Given this list of marker genes Mgat4d (MGAT4 family, member C), Srd5a3, Entpd5, Dolpp1, Nus1, Tusc3, Rpn2, Alg2, Pmm1, Rpn1, Frey1, Tmem258, Mgat2, Mgat4a, B4galt7, Dolk (NCBI Gene Id 227697), Mgat3, Cwh43, Uggt1, Alg3, Alg5, Pgm3, Ddost, B4galt1, Alg14, Gfpt1, Mgat4f, Krtcap2, Serpina1b, Uggt2, St3gal1 (NCBI Gene Id 414082), Gorasp1, Ext2, Mgat5, Alg12, Mgat1, St6gal1, Pmm2 (phosphomannomutase 2), Mgat4c (MGAT4 family, member C), Slc39a8, Serpina1a, Alg8, Mlec, Rft1, Stt3a, Alg11 (ALG11 alpha-1,2-mannosyltransferase), Mgat4e, Alg9, Fut9 (NCBI Gene Id 14348), Tmem165 (transmembrane protein 165), Gfpt2, Alg13, Ube2j1 (NCBI Gene Id 80530), Mogs, Derl3, Pate6 (prostate and testis expressed 6), Mgat4b, Fut4, Alg10b, Dhdds, Stt3b, Alg6, Alg1, Dpagt1, Fut8, Mgat5b (NCBI Gene Id 268510), Magt1, Dpm1, Ost4, Dad1, here is a description of the gene set: studied in species Mus musculus A protein glycosylation process in which a carbohydrate or carbohydrate derivative unit is added to a protein via the N4 atom of peptidyl-asparagine, the omega-N of arginine, or the N1' atom peptidyl-tryptophan. Mouse Gene Set: GOBP_PROTEIN_N_LINKED_GLYCOSYLATION